Given this list of marker genes CD109, ELAPOR2, MAFG, PKP1, MIR125B1, EXTL3, TP63, GRHL1, SGPP1, FGF2, BMP4, CYP27B1, ERRFI1, KEAP1, KRT2, ABCA12, KRT36, NME2, KLF7, HES1, MACROH2A2, HOXA7, NAB1, OVOL2, MACROH2A1, SFN, TMEM79, NCOA3, NUMA1, VDR, ZFP36L1, MAFF, ESRP1, SFRP4, FOXC1, HES5, NOTCH1, MYCN, DLL1, PRKCH, SULT2B1, KRT10, SRSF6, ROCK1, HEY2, MYCL, EZH2, NAB2, AQP3, PLAAT4, PPARD, REG3A, ROCK2, ETV4, MED1, KRT84, ZFP36, MSX2, GDF3, REG3G, SPRR5, PTCH1, ATOH1, IL20, KDF1, TRIM16, TFAP2C, PTCH2, ALOX15B, ZBED2, here is a description of the gene set: species: Homo sapiens Human Gene Set: GOBP_REGULATION_OF_EPIDERMIS_DEVELOPMENT Any process that modulates the frequency, rate or extent of epidermis development.